Given this list of marker genes NCF1, NCF4, NOXO1, NCF2, DUOX1, NOX3, RAC2, RAC3, CYBA, NOXA1 (NCBI Gene Id 10811), NCF1C, DUOX2, NOX5, NOX1, NOX4, RAC1, CYBB, NCF1B, here is a description of the gene set: species: Homo sapiens A enzyme complex of which the core is a heterodimer composed of a light (alpha) and heavy (beta) chain, and requires the cytosolic regulatory subunits at least NCF1/p47-phox, NCF2/p67-phox, NCF4/p40-phox and the small GTPase RAC1 or RAC2 for activity. Functions in superoxide generation by the NADPH-dependent reduction of O2. Human Gene Set: GOCC_NADPH_OXIDASE_COMPLEX